Given this list of marker genes Dpyd, Il10ra, Cd84, Loxl3, Ppp1r18, Gapt, Itgam, Capg, Tcirg1, Igsf6, Ncf2 (neutrophil cytosolic factor 2), Zfp36l2, Spp1, Tnfrsf1b, Sft2d2, Slc7a7, Tgfbr1, Itgax, Rnase6, Slc1a5, Samsn1, Lhfpl2 (lipoma HMGIC fusion partner-like 2), C3, C1qc, Nckap1l, Elf4, Tyrobp, Creb3l2, Plek, Npc2, Hlx, Stat5a, Sh2b3 (NCBI Gene Id 16923), Runx3, Lyl1, Cytl1, Tmem106a (transmembrane protein 106A), Il13ra1, Apbb1ip, Cd37, Itgb2, Gpx1, Fkbp15, Cd4, Cxcl16, Maf, Adap2, Kcne3, Gal3st4, Nrros, Il18, Hcls1, Bin2, Rgs1, Abcc4, Pycard, Rbm47, Rps6ka1, here is a description of the gene set: Mouse Gene Set: WP_TYROBP_CAUSAL_NETWORK_IN_MICROGLIA Tyrobp causal network in microglia studied in species Mus musculus